The following is a description of a gene set: studied in species Homo sapiens A cell junction that forms a connection between two or more cells of an organism; excludes direct cytoplasmic intercellular bridges, such as ring canals in insects. Human Gene Set: GOCC_CELL_CELL_JUNCTION, and this is the list of marker genes: PPP1CA, GJA3, VSIG10, LLGL1 (LLGL scribble cell polarity complex component 1), PLEKHG5, RAP1B, MPP7, FLOT2, PATJ, FLNA, CCN3, RANGRF, CFL1, ARVCF, PTPRK, CTNNA2, PLXDC1, B4GALT1, LRRC7, ATP1B1, PTPRM, CYTH3, HEG1, IQGAP3, CLDN5, NGFR, RDX, FRMD4B, PDLIM2, CAV3, SDCCAG8, MARVELD2, TJP1, NOTCH1, STRN, TJAP1, MICALL2, CDH1, FGF13, RND1, DSG3, CDH5, SMAD7, FER, ITGB3, AQP3, PPP1R9B, PERP, VCL, CD2, CDH18, KCNJ2, GRHL2, ANKRD23, FLCN, ILDR2, PKP2, KIAA1210, TJP2, SPTBN4, PRKCH (NCBI Gene Id 79030), ACTR3, DDX6, PKP1, GJA5, FAT2, COL13A1, POLDIP2, EPHA2, NHERF4, GJC3, PALS1, CCDC88C, DLL1, VASP, ZAP70, PAK2, AJAP1 (adherens junctions associated protein 1), CGNL1, SIRT2, ARHGEF2, KIT, WNK4, DLG2, GJB7 (NCBI Gene Id 730838), ADGRL3, GJA9, ARHGEF6, CD99L2, USP53, PPL, SSX2IP, TJP3, ECT2, EIF4G2, PDLIM7, CDK4, DPP4, CDH26, CLDN20, JAM3, S100A11, LDB3, GJA1, JUP, RIGI, SGCA, FLRT2, BAIAP2, OCEL1, PKP4, CEACAM1, SIPA1L3, CDH17, IGSF21, KCNA2, PDZD2, PRKCD, YWHAH, VAMP5, RPGRIP1L, PARD6A, APC, NECTIN2, NF2, CGN, ADCYAP1R1, PARD6B, BLOC1S6, PKN2, PDZD11, OPALIN, MAGI1, RAP2C, RHOA, OBSL1, CDH7, CD3E, CDH6, SYMPK, PDLIM3, PTPRJ, ARHGAP17 (Rho GTPase activating protein 17), SCRIB, ALOX15B, TNK2, TMOD3, WAS, EPPK1, CLDN25 (claudin 25), XIRP2, KRT80, PLEKHG4B, FZD5, FGFR4, SCN5A, DNMBP, AMOTL1, ADD1, MLC1, CLDN11, CXADR (NCBI Gene Id 95792), LIN7C, SCN1A, RAP2B, RAB10, ANK3, PODXL, CDH24, PCDH9, NCK1, LSR, CLDN23, SHROOM4, DLG1, CYTH1, SLC2A1, IGSF5, LAT, RASIP1, DBN1, CADM3, CASK, CDH22, ESAM, NPHS1, DLG5, PLEKHA7, CCDC85C, LIMS1, SH3KBP1, CDH9, PLPP3 (phospholipid phosphatase 3), PRICKLE4, PARD6G, TMEM204, MPP1, LUZP1, ZYX, DSC3, CLDN10 (claudin 10), CDC42EP1, KRT8, PVR, NPHP1, CDH15, AMTN, ANXA2, LIN7A, MARVELD3, KIFC3, MYH9, LLGL2, PCDHA10, FRS2, CDH11, APOLD1, MPP2, FRMD5, GJC2, CCDC85A, EFNB2 (NCBI Gene Id 1948), CRB1, CLDN19, STEAP1, SPTBN2, JAML, DSG1, PAK1, LIMS2, PDLIM5, PRKCI, ADAM15, DAG1, PCDH12 (NCBI Gene Id 51294), SCN1B, EZR, MAGI2, CTNNB1, CLDN12, ASH1L, LYN, NECTIN1, PACSIN2, CDH3, UBN1, KIRREL3, NRAP, NPHP4 (NCBI Gene Id 261734), PRKCZ (protein kinase C zeta), NECTIN3, WTIP, MAP2K2, CNKSR1, PGM5, GRIA1, TRPC6, CDC42EP4, KCNA5, EVPL, ACTG1, COL17A1 (collagen type XVII alpha 1 chain), GJA8, ADAM17, BVES, NEXN, YAP1, PRKD1, PTK7, PDLIM4, FHOD1, VSIG10L2, PMP22, IGSF11, TIAM1, CNN2, PKP3 (NCBI Gene Id 11187), FXYD1, MYH2, SAPCD2, SGSM3, PTPRU (NCBI Gene Id 10076), PTPN6, UBA1, CD53, CDSN, TGFBR1, DES, FGFRL1, CDC42BPB, CLDN8, ADGRB1, SYNPO, DSC2 (desmocollin 2), SLC9A1, CDH2, VAV1, CDCA3, FRMD4A, CNTNAP2, SRC, P2RX7, TWF1, CLDN22, PXN, EFNA5, RAB13, CDH12, TRAF4, ABCC2, GJA10, PDCD6IP, PDXP, CDH13, NDRG1, NPHS2, ADD3, SKAP1, PCDHGA12, PRKCG, CNN3, GAB1, SLC31A1, CLDN3, CTNNA3, LIN7B, DSG4, AKAP6, BAIAP2L1, AJM1, CDH19, CDH8, SLC8A1, KLHL24, POF1B, PARD3B, CNTNAP1, KRT18, F11R, SHROOM3, KRIT1, OCLN, MAPK15, STX3, CLDN4, C1QTNF5, CLDN2, GJD4, ANXA1, FSCN1, GJB2, SHROOM1, PALS2, CYTH2, PIP5K1C (phosphatidylinositol-4-phosphate 5-kinase type 1 gamma), SHROOM2, AJUBA, CLMP, YBX3, CTNND2, SCN4B, FAT1, SYNM, MTDH, MAGI3, AFDN, CTNND1, LCK, PNN, TRIM29, VEGFA, PARK7, TSPAN33, FMN1, CLDN18, MSN, PCDH1, SLC2A2, PANX3, PAK4, EHD4, DSG2, CLIC4, STARD10, SV2A, VEZT, PKD2, VANGL2 (NCBI Gene Id 57216), WDR1, IQGAP1, MICALL1, SNAP23 (synaptosome associated protein 23), FLOT1, ABCB11, TCHP, PIK3CA, CLDN24, ABCB4, LAMA1, CALB2, PANX1, EPHA4 (NCBI Gene Id 401031), DSP, CDH4, WWTR1, CRB3, GJB6, HPN, GJD2, GRB2, GJE1, MPP3, WNK3 (WNK lysine deficient protein kinase 3), AOC1, AHNAK, TLN1, AMOTL2, ABI2, LIMD1, MAP3K1, PDLIM1, ITGA5, TEK, GJB3, THEMIS, TMEM47, MPP4, LCP2, CADM1, CLDN17, XIRP1, CADM4, CCND1, EPB41L4B, FERMT2, ACTN1, DLG4, AHI1, PECAM1, NFASC, PARD3, BAIAP2L2, KAZN, ATP2A2, NHS, TNKS1BP1, ITGB1, CLDN7, TENM2, EPB41L5, FRMD6, GJA4, FLRT1, PIK3R1, ACTB, KIRREL2, AMOT, CTNNA1, CDH20, CLDN15, FLRT3 (NCBI Gene Id 23767), AKT1 (AKT serine/threonine kinase 1), TRPV4, CLDN9, RHO, HEPACAM, LAMA3, VAPA, CLDN16, DLG3, CD2AP, ARHGAP24, CDC42BPA, GJD3 (NCBI Gene Id 125111), CORO1A, CDC42 (NCBI Gene Id 998), CDH10, SH3BP1, GJB1, ILDR1, ADAM10, BMPR2, FZD4, GJB4, MYADM, SORBS1, TMEM65, ITK, CLDN1, TRPC4, DSC1, MXRA8, NIBAN2, SDCBP, CLDN14, WASF2, CCDC85B, CAMSAP3, JCAD, CLDN34 (claudin 34), JAG1, SPECC1L, GJB5, ATP1A2, STXBP6, CLDN6, HMCN1, MYO1E, CSK, TBCD, AQP7, MYH1, FRMPD2, CRB2, MPDZ, KIRREL1, ANK2, EPCAM, EPB41L3, NECTIN4, FBF1, RAPGEF2, CDHR3, GJC1, JAM2